The following is a description of a gene set: Human Gene Set: GOBP_RELAXATION_OF_MUSCLE A process in which the extent of muscle contraction is reduced. Muscle relaxation can involve a number of processes including the removal of calcium from the cytoplasm to the sarcoplasmic reticulum lumen through the action of Ca2+ ATPases. In some muscles, calcium-independent pathways also play a role in muscle relaxation by decreasing the phosphorylation state of myosin light chain. studied in species Homo sapiens, and this is the list of marker genes: ADORA2B, SRI (sorcin), PRKG1, IRAG1, RGS2, ATP2A2, CAMK2D, GSN, PIK3CA, NEUROG1, ACTN3, GSTM2, P2RX4 (NCBI Gene Id 5025), PDE4B, ATP1A1, ABCC8, PLN, KCNJ2, TIFAB, ATP2A1, HRC, SLN, DCANP1, KBTBD13, SOD1, GRK2, PDE4D, CHGA, ATP1A2, SLC8A1, MIR153-1, ATP1B1, P2RY1, GUCY1A1